Given this list of marker genes Dpm1, Lypd1, Pign, Pigu, Alppl2, Akp3, Gpihbp1, Ly6e, Otoa, Cntn3, Pigk, Pigl, Rtn4rl2, Gpld1, Negr1 (neuronal growth regulator 1), Psca, Mdga1, Pigv, Ceacam1, Pgap1, Pigw, Reck, Vnn1, Prnd, Lypd2, Psg29, Msln, Cd52, Meltf (melanotransferrin), Pigc, Prss21, Ntm (neurotrimin), Bst1, Lypd6b, Lypd3, Spaca4, Lypd4, Gm20716, Thy1, Pigm, Lsamp, Ly6g6c, Pigq, Sprn, Pigh, Pigs, Prss41, Ly6d, Art4, Fcgr4, Ly6k, Dpm3, Gpaa1, Cntn5, Pigyl, Izumo1r, Plaur, Lypd5, Alpi, Cpm (carboxypeptidase M), Pigp, Dpm2, Art3 (ADP-ribosyltransferase 3), Pigz, Xpnpep2, Nrn1, Tex101, Alpl, Pigb, Pigf, Psg22, Gp2, Nrn1l, Ceacam2, Folr2, Opcml, Tecta, Pigx, Piga, Psg18, Plet1, Cd109, Pigt, Pigg, Ly6h, Lypd8, Tectb, Ly6g6d, here is a description of the gene set: species: Mus musculus Mouse Gene Set: REACTOME_POST_TRANSLATIONAL_MODIFICATION_SYNTHESIS_OF_GPI_ANCHORED_PROTEINS Post-translational modification: synthesis of GPI-anchored proteins